Given this list of marker genes GNAI2, GNAI3, AKT2, PIK3CB, PIK3CD, GNAI1, AKT3, ADRB2, BAD, PIK3CA, AKT1, here is a description of the gene set: Pathway Definition from KEGG: (Nicotine,NNK) -> ADRB2 -> GNAI -> PI3K -> PIP3 -> AKT -| BAD Human Gene Set: KEGG_MEDICUS_ENV_FACTOR_NICOTINE_NNK_TO_PI3K_SIGNALING_PATHWAY species: Homo sapiens Nicotine/NNK to PI3K signaling pathway. Pathway ID: N01348. Pathway type: Env factor. Pathway class: nt06214 PI3K signaling.